The following is a description of a gene set: Increased CD4:CD8 ratio An abnormal elevation of the relative proportion of CD4+ to CD8+ T cells. studied in species Homo sapiens Human Gene Set: HP_INCREASED_CD4_CD8_RATIO, and this is the list of marker genes: CD28, CTLA4, TNFRSF1B, ZAP70, POMP, PSMB10